The following is a description of a gene set: studied in species Homo sapiens Genes predicted to be targets of miRBase v22 microRNA hsa-miR-374a-3p in miRDB v6.0 with MirTarget v4 prediction scores > 80 (high confidence targets). Human Gene Set: MIR374A_3P from publication Chen Y, Wang X (PMID 31504780), and this is the list of marker genes: OR6A2, CNTN1, NCOA7, FAF2, SLC24A2, CLDN22, GSTA2, PABIR3, VBP1, PRKAR2B, NOL8, RFX7, C12orf50, PLPPR5, GCFC2, ELOVL7, ZBTB26, CLEC1A, RHOA, GPR155, ZMAT3, CCDC28A-AS1, PTPN12, PIAS1, YIPF4, KLHL24, CREBBP, SCAF11, DEXI, TDRD5, ANO6, ZDHHC13, SORBS2 (NCBI Gene Id 8470), FUT9, KDSR, CALHM2, PTPRG, SPARC, SHISA2, PHF20L1 (PHD finger protein 20 like 1), KCND2, STAT3, PHF3, NR4A2, SP8, TRPS1, RANBP17, GSTA1, RAET1E, GPBP1, HSP90AA1, AOPEP, CAB39L, OPRM1, CDS1, ZNF460, ZNF655, ARHGAP42, EIF3A, GPR85 (NCBI Gene Id 54329), LGR4, CCNDBP1, PLD1, NPHP1, IL2, SOWAHC, ABHD3, OXR1, CREG1, PIK3CG, NAB1, RBM27, HS2ST1, PLPPR4, WNT7A, BTF3, SCAF8, HOMER1, GOLGA4, PPP2R5E, ADCYAP1, COPS8, ATPAF1, UBA5, EEA1, USP49, SP1, PARD3B, WNT3, PROX1, BMPR2, MED19, NEGR1, C3orf62, ERC2, SLC41A1, SH3GLB1, BCCIP, ABCC10, USP10, PCMTD1, CHST9, GLRB, LARP4, ZBTB1, ZC3H12C, RNF4, GNPTG, TRPC5, MTRR, GEN1, GLRX, SLC4A11, HMBOX1, MTX3, LONP2, RNGTT, MAP2, SLIT2, ZBTB10, TFAP2B, UNC80, POLR1F, KPNB1, ARRDC3, SLC35A5 (solute carrier family 35 member A5), FKTN, PHYH, SMARCE1, LACTB, OGN, ZNF470 (NCBI Gene Id 388566), ZNF562, KCNJ3, UBE2K, ZFAND1